Given this list of marker genes Me2, Odc1, Raf1, Adcy1, Hacd4, Phykpl, Eno4, Adcy9, Gnaz, Pam, Guca2b (NCBI Gene Id 50499), Usb1, Sgpl1, Ncs1, Fh1, Oaz2, Alad, Cth, Asl, Hmga1, Tsen34, Cyp1b1, Pts, Mgst3, Hacd3, Ddc, Rnase1, Polg, Hmgb1, Umps, Hmgcl, Nthl1, Me3, Tpi1, Dglucy, Pm20d1, Adcy8, Adcy6, Gucy1b2, Mocos, Hoga1, Neil3, Gucy2g (guanylate cyclase 2g), Tbxas1, Ppcdc (phosphopantothenoylcysteine decarboxylase), Hmga1b, Alox5ap, Fahd1, Scly, Ltc4s, Kyat3, Aldob, Cdyl, Ddt, Echdc2, Uroc1, Thnsl2, Gnai1, Fech, Hdc, Dera, Car9, Npr2, Urad, Pisd, Xrcc5, Gad1, Nherf4, Car11, Chac2, Ogg1, Oaz1, Ptgis, Amd2, Car6, Uxs1 (UDP-glucuronate decarboxylase 1), Mgst2, Uros, Calm3, Got1, Gucy1b1, Rnaset2b, Gnas, Guca2a, Car5b, Tsen2, Ftcd, Aco1, Pcbd1, Chac1, Shmt1, Bst1, Pdxdc1, Hmces, Park7 (NCBI Gene Id 57320), Adcy4, Eno1, Rps3, Glo1, Rnase2b, Mlycd, Guca1b, Calm1, Cenpv, Ilvbl, Tha1, Csad, Azin2, Adcy2, Poll, Hmbs, Polq, Srr, Cyp1a2, Hacd2, Mocs1, Cyp1a1, Gatd1, Endou, Gucy1a2, Car3, Adsl, Aco2, Armt1, Ggcx, Coq4, L3hypdh, Sdsl, Adcy7, Gad2, Npr1 (NCBI Gene Id 99760), Hccs, Car4, Echdc1, Car12, Hacd1, Calm2, Eno2, Ldc1, Aldoa, Amd1, Car13, Hmgcll1, Car2, Gucy2c, Etnppl, Adgrv1, Hal, Car5a, Car1 (NCBI Gene Id 99925), Adcy10, Car8, Kyat1, Oaz3, Hmga2, Car10, Car15, Echs1, Shmt2, Adcy3, Rnaset2a, Xrcc6, Eno1b (NCBI Gene Id 433182), Car7, Aloxe3, Aldoc, Cbs, Me1, Guca1a, Tkfc, Tyw1, Npl, Ggct, Naxd, Ehhadh, Gldc, Alkbh1, Fasn, Neil2, Ptges2 (NCBI Gene Id 96979), Pcbd2, Acmsd, Adcy5, Hsd17b4, Paics, Gucy2f (guanylate cyclase 2f), Azin1, Grm7, Polb, Pck2, Hadha, Gstm4, Eno3, Car14, Auh, Neil1, Cd38, Pck1, Clybl, Gmds, Aldoart2, Gucy2e, Ireb2 (NCBI Gene Id 64602), Aldoart1, Rsad2, Ggact, Urod, Sds (NCBI Gene Id 231691), Cyp2s1, Gucy1a1, Tgds, Hacl1, Echdc3, Apip, Acod1 (NCBI Gene Id 16365), Rgs2, Mvd, Gucy2d, Ear14, Cyp17a1, Gadl1, here is a description of the gene set: Mouse Gene Set: GOMF_LYASE_ACTIVITY species: Mus musculus Catalysis of the cleavage of C-C, C-O, C-N and other bonds by other means than by hydrolysis or oxidation, or conversely adding a group to a double bond. They differ from other enzymes in that two substrates are involved in one reaction direction, but only one in the other direction. When acting on the single substrate, a molecule is eliminated and this generates either a new double bond or a new ring.